Given this list of marker genes AGER, NR1D1, TTBK1, ZEB2, IFNG, MIR181B1, TNF, VIM, IL1B, GFAP, NF1, ROR1, EIF2B5, DLL1, SMO, C5AR1, PLP1, LRP1, APP, MAPT, ADORA2A, LAMC3, NAGLU, S100A9, CDK6, MIR181C, IFNGR1 (NCBI Gene Id 3459), KRAS, TLR4, TREM2, DRD1 (NCBI Gene Id 1812), LDLR, IL6, MIR142, LAMB2, C1QA, FPR2, S100A8, PSEN1, CNTF, TSPAN2 (tetraspanin 2), POU3F2, GRN, here is a description of the gene set: Human Gene Set: GOBP_ASTROCYTE_DEVELOPMENT species: Homo sapiens The process aimed at the progression of an astrocyte over time, from initial commitment of the cell to a specific fate, to the fully functional differentiated cell. An astrocyte is the most abundant type of glial cell. Astrocytes provide support for neurons and regulate the environment in which they function.